Given this list of marker genes SATB2, HECTD4, PDCD4, GMNN, CLIC4, ERLIN1 (ER lipid raft associated 1), ETFDH, CFAP20, TRPV2, SLC31A2, PHF8, CSGALNACT2, ANKRA2, ZNF318, PDE4DIP, NXT2, NMRK1, MPHOSPH9, RETREG2, AGA, LYPD1, ANP32E, BNIP3L, ARHGAP26, ALDH7A1, TNKS2, BCOR, KLHDC2, CTNNAL1, STARD5, GNB5, WASHC3 (WASH complex subunit 3), SBNO1, MED4, FOXD1, ABCG2, PHLPP1, PCOLCE2, PPM1E, RHOQ, MARCHF5, IMPA2, TBC1D31, NUCB2, IL17RB, MT1H, CDC42EP1, RUFY3, SAP30, SAC3D1, KLHL7, EPB41L4B, PLSCR1, HSPA2, RBM47, TMPO, CXCR4, TUBB6, GLRX, ZBTB1, THAP9-AS1, RPS6KA2, NUDT1, SLCO3A1, PIM2, ISG20, JAG1, DPYSL2, LHX6, PSIP1, WDR46, CA8, GMCL1, PXDN, ARL4C, ABCD3, NAGPA, SOBP, LNPEP, AP2B1, TPI1, SNX7, EMP3, ULK2, MARCHF3, PRKAR2B, RPL23AP1, BAG2, USP25, SEC24A, CRIM1, TACC2, MMD, ALCAM, FYN, SRD5A1, EZH2, KCNS3, HSPA12A (NCBI Gene Id 9893), RNGTT, NARF, ICAM3, NCOA1, TMEM30B, ASRGL1, STK17A, KLF11, FZD7, HIGD2A, PTBP3, MGAT2 (NCBI Gene Id 4247), SLC1A4, PLCXD1, OVOL2, H1-10, MEMO1, IDS, GRB10, DNAJB5, MAPKAPK2, FABP5, NMI (N-myc and STAT interactor), NGLY1, VCPKMT, here is a description of the gene set: studied in species Homo sapiens The v-Myb oncoprotein encoded by Avian Myeloblastosis Virus is highly oncogenic, induces leukemias in chickens and mice and transforms immature hematopoietic cells in vitro. The v-Myb protein is a mutated and truncated version of c-Myb, a DNA-binding transcription factor expressed in many cell types that is essential for normal hematopoiesis. Previous studies suggested that two types of differences, DNA binding domain mutations and the deletion of a C-terminal negative regulatory domain were important for increasing the transforming activity of v-Myb. Here, we combined structure-function studies of the v-Myb and c-Myb proteins with unbiased microarray-based transcription assays to compare the transcriptional specificities of the two proteins. In human cells, the v-Myb and c-Myb proteins displayed strikingly different activities and regulated overlapping, but largely distinct sets of target genes. Each type of mutation that distinguished v-Myb from c-Myb, including the N- and C-terminal deletions, DNA binding domain changes and mutations in the transcriptional activation domain, affected different sets of target genes and contributed to the different activities of c-Myb and v-Myb. The results suggest that v-Myb is not just a de-repressed version of c-Myb. Instead, it is a distinct transcriptional regulator with a unique set of activities. Human Gene Set: LIU_VMYB_TARGETS_UP Genes up-regulated in MCF-7 cells (breast cancer) by overexpression of v-MYB oncogenic varian of CMYB off adenovirus vector. from publication Liu F, Lei W, O'Rourke JP, Ness SA (PMID 16205643)